Given this list of marker genes CTNNA1 (catenin alpha 1), LAMC1, LIMS2, SLC2A10, ITGB1BP1, TIMP1, LOXL3, LAMB1, PRKD1, LAMA1, SERPINE1, LAMA2, CD63, EMP2, PLAU, LIMS1, CD177, MIR92B, VTN, BST1, PHACTR4, LAMB2, NID1, FLNA, here is a description of the gene set: Any process that modulates the frequency, rate or extent of integrin-mediated signaling pathway. Human Gene Set: GOBP_REGULATION_OF_INTEGRIN_MEDIATED_SIGNALING_PATHWAY studied in species Homo sapiens